The following is a description of a gene set: Alopecia A noncongenital process of hair loss, which may progress to partial or complete baldness. species: Homo sapiens Human Gene Set: HP_ALOPECIA, and this is the list of marker genes: CLDN1, ADA, BTK, EOGT, EDAR, SLC39A4, ETS1, MANF, TNFAIP3, XPC, KDSR, ANTXR1, UBR1, HLA-DQA1, WNT10A, COL3A1, PNPLA1, PNPLA6, HLA-DRA, KRT83, IL7R, ACVR1, KRT74, ERCC3, ATR, NOTCH1, HFE, DOCK6, GATA1, DNASE1, RHOA, SLC30A2, KDM1A, SMARCA2, TNIP1, CWC27, NPM1, DOLK, AP1B1, IRAK1, OFD1, SREBF1, KRT85, ARHGAP31, PERP, KIAA0319L, FAS, STAT4, JAZF1, ZPR1, LSS, LMNA, ZMPSTE24, RNU4ATAC, BTNL2, KLHL24, UQCRFS1, CD28, PORCN, WRN, DLL4, H6PD, KRT16, TRAC, RECQL4, FGFR1, NOP10, BAP1, TTC7A, GJB4, MCCC2, CHD7, KRT5, STUB1, USB1, GNA11, RIN2, NRAS, IKBKG, PADI3, HLA-B, DVL1, AEBP1 (AE binding protein 1), LAMC2, PSMB10, IPO8, TNFSF4, KRT14, FLNA, SULT2B1, CASR, CRELD1, LAMB3, BLK, SPP1 (secreted phosphoprotein 1), KRT81, C4B, NECTIN1, JUP, RTEL1, EXOSC2, HTRA1, ABCA12, ARMC5, ALMS1, TERC, FTL, FZD2, SNRPE (NCBI Gene Id 6635), TMPRSS6, TREX1, RBPJ, SLITRK1, ABCD1, BCS1L, FOXP3, CSTB, DDB2, NECTIN4, PRKCD, HRURF, CERS3, ALX4 (NCBI Gene Id 64068), GTF2H5, HLA-DRB1, IL2RA, CTLA4, ABHD5, GJA1, ERCC5, LIG4, DSG4, DCAF17, FOXN1, VDR, HLCS, EDARADD, MPLKIP, ODC1, IRF5, RAG2, IL10, ERCC4, PIK3R1, TRPV3, KANSL1, UBE2L3, CYP11B1, KRT6B, FCGR3B, MBTPS2, KRAS, SDR9C7, COL18A1, EBP, TLR7, MECP2, PDCD1, ITGB6, UROS, TGM3, NIPAL4, CTC1 (CST telomere replication complex component 1), CR2, AARS1, HEPHL1, DCLRE1C (NCBI Gene Id 64421), LAMA3, TP63, CHD6, SOX18, GTF2E2, POLD3 (DNA polymerase delta 3, accessory subunit), ASL, AHSG, AIRE, IGHG1, DMXL2, RBM28, RIPK4 (receptor interacting serine/threonine kinase 4), PTPN22, BMP2, ATP7A (ATPase copper transporting alpha), NFKB1, ALOXE3, PARN, ITGB4, TINF2, POLR3A, PI4KA, KDF1, RAG1, KCTD1, PLEC, TGM1, NFKB2, GNAS, KDM5C, XPA, PXK, NHP2, TNFRSF1B, DSP, RNF113A, IL2RG (interleukin 2 receptor subunit gamma), ECM1, GJB3, ALOX12B, FCGR2B, SLC27A4, FAM111B, COL17A1, NSDHL, ZNF341, SASH1, TARS1, ERCC2, CARS1, PEX7, LIPH, C4A (complement C4A (Chido/Rodgers blood group)), DVL3, TERT, KRT6A, BLM, CDSN, P4HA2, KRT86, COL7A1, NXN, SLC29A3, RPL21, PRKACA, RMRP, MAP2K2, ANAPC1 (anaphase promoting complex subunit 1), ITGAM, WRAP53, APCDD1, FLI1, MOGS, WNT5A, BANF1, GJB2, ROR2, LORICRIN, EDNRA, HRAS, HLA-DQB1, BTD, GJB6, LPAR6, KRT17, DKC1, PKP1, HR, MGP, EPS8L3, UROD, SAT1, TYMS, BANK1